Given this list of marker genes Tuba1a, Tuba3b, Gjc2, Gjb4 (gap junction protein, beta 4), Gjb6, Tuba8, Gjd3 (gap junction protein, delta 3), Gjb5, Gjb2, Tubb2a, Tuba4a, Gja8, Tubal3, Gja10, Tubb4a, Tuba3a, Gjb3, Gjb1, Gjd4 (NCBI Gene Id 353078), Gja1, Gja5, Tubb4b, Gjc1, Gja3, Tubb1, Gjd2, Tubb2b, Tuba1b, Tuba1c, Tubb6, Tubb3, Gja4, here is a description of the gene set: species: Mus musculus Gap junction assembly Mouse Gene Set: REACTOME_GAP_JUNCTION_ASSEMBLY